The following is a description of a gene set: studied in species Homo sapiens The process that modulates the frequency, rate or extent of granule cell precursor proliferation. Human Gene Set: GOBP_REGULATION_OF_CEREBELLAR_GRANULE_CELL_PRECURSOR_PROLIFERATION, and this is the list of marker genes: CEND1, SHH, IGF1, SLC6A4, EGF, FGF2, SKOR2, GPR37L1